Given this list of marker genes Grid1, Grin3a, Gria1, Grin2c, Gria3 (NCBI Gene Id 73036), Grik5, Gria2, Grin3b, Gria4, Grik2, Grik1, Grin2b, Grin2d, Grid2, Grik3, Grin2a, Grin1, Grik4, here is a description of the gene set: studied in species Mus musculus Mouse Gene Set: GOMF_GLUTAMATE_GATED_RECEPTOR_ACTIVITY Catalysis of the transmembrane transfer of an ion by a channel that opens when glutamate has been bound by the channel complex or one of its constituent parts.